Given this list of marker genes OR52N4, ITGB8, RFX8, NAMPT, MET, LIF, IL36RN, TRPA1, MSC, AK4, IL6, BCL2A1, CYP1A1 (cytochrome P450 family 1 subfamily A member 1), CHST7, here is a description of the gene set: studied in species Homo sapiens Human Gene Set: HARALAMBIEVA_PBMC_M_M_R_II_AGE_11_22YO_VACCINATED_VS_UNVACCINATED_LOW_ANTIBODY_RESPONDERS_TO_TREATMENT_7YR_UP from publication Haralambieva IH, Zimmermann MT, Ovsyannikova IG, Grill DE, Oberg AL, Kennedy RB, Poland GA (PMID 27529750) BACKGROUND: There are insufficient system-wide transcriptomic (or other) data that help explain the observed inter-individual variability in antibody titers after measles vaccination in otherwise healthy individuals. METHODS: We performed a transcriptome(mRNA-Seq)-profiling study after in vitro viral stimulation of PBMCs from 30 measles vaccine recipients, selected from a cohort of 764 schoolchildren, based on the highest and lowest antibody titers. We used regression and network biology modeling to define markers associated with neutralizing antibody response. RESULTS: We identified 39 differentially expressed genes that demonstrate significant differences between the high and low antibody responder groups (p-value <= 0.0002, q-value <= 0.092), including the top gene CD93 (p < 1.0E-13, q < 1.0E-09), encoding a receptor required for antigen-driven B-cell differentiation, maintenance of immunoglobulin production and preservation of plasma cells in the bone marrow. Network biology modeling highlighted plasma cell survival (CD93, IL6, CXCL12), chemokine/cytokine activity and cell-cell communication/adhesion/migration as biological processes associated with the observed differential response in the two responder groups. CONCLUSION: We identified genes and pathways that explain in part, and are associated with, neutralizing antibody titers after measles vaccination. This new knowledge could assist in the identification of biomarkers and predictive signatures of protective immunity that may be useful in the design of new vaccine candidates and in clinical studies. Genes up-regulated in peripheral blood mononuclear cell vaccinated vs unvaccinated in adolescent/young adults (11-22) (low antibody responders to treatment) after exposure to M-M-R II, time point 7Y